The following is a description of a gene set: Human Gene Set: HP_ACNE Acne A skin condition in which there is an increase in sebum secretion by the pilosebaceous apparatus associated with open comedones (blackheads), closed comedones (whiteheads), and pustular nodules (papules, pustules, and cysts). species: Homo sapiens, and this is the list of marker genes: CDH23, IFNGR1, WNT4, GJB6, PSEN1, RBP4, RREB1, ARVCF, CYP11B1, USP8 (NCBI Gene Id 9101), PSTPIP1, POFUT1, TLR4, ECM1, UBAC2, FGFR2, IL12A, PSENEN, ERAP1, GP1BB, HYOU1, LHCGR, TBX1, AIP, HIRA, ESR1, SEC24C, PAPSS2, XIAP, IKBKB, CCR1 (C-C motif chemokine receptor 1), LPIN2, BRAF, MEFV, UFD1, GJB2, PTPN6, JMJD1C, KDF1, IL12A-AS1, HLA-B, IL23R, NR3C1, XYLT1, C4A, HPGD, MEIS2, TP53, STAT4, USP48, AGA, IL10, ATRX, PRKACA, KDM1A, AR, SH3PXD2B, H6PD, FAS, NCSTN, GNAS, GPR101, KLRC4, SLCO2A1, ARMC5, POGLUT1, COMT, KRT5